The following is a description of a gene set: Human Gene Set: HP_CLUMSINESS Lack of physical coordination resulting in an abnormal tendency to drop items or bump into objects. species: Homo sapiens Clumsiness, and this is the list of marker genes: TTN, SLC22A5, PANK2, SLC52A3, BSND, TPM3, UBE3A, FRRS1L, MAPT, PRNP, POLR3A, PMP22, GPRC5B, TSHB, HNRNPA1, GRIN2A, CLTC, NKX2-1, HTT, SDHA, MPZ, PLA2G6, SPTAN1, MORC2, ATP2B3, DCC (DCC netrin 1 receptor), ASAH1, AQP4 (aquaporin 4), GALC, CLCN1, CAV3, SCO2, CHD8, CLCNKB, KCNA1, DNAL4, ATXN3, NR4A2 (nuclear receptor subfamily 4 group A member 2), MICU1, PAK3 (NCBI Gene Id 5063), PSAP, ARSA, CPLX1, BCKDK, RNF125, NTN1, TWNK, AFF2, CAPN3, SLC52A2, DARS2, GALT, RNF168, MYPN, KCNC3, MAN2B1, TBC1D24, ACTA1, NEB, TPP1, TTPA, SLC39A14, CLN8, GJB1, KLHL41, ACOX1 (NCBI Gene Id 8308), SLC2A3, ATP7B, CWF19L1, FXN, TIA1, MECR, HAX1, SQSTM1, SNRPN, TPM2, KDM4B, KBTBD13, CLN5, DEAF1, ALG13, AASS, CLCNKA, HEPACAM, SYNE1, RAD51